Given this list of marker genes Srpk3, Slc5a10 (NCBI Gene Id 78839), Aoc3, Ppp1r27, Cend1, Rbfox3, Mroh2a, Bricd5, Mslnl, Dnlz, Mmp25, Efcab12, Spata31g1, Ftcd, Pde1b, here is a description of the gene set: studied in species Homo sapiens Tha authors analyzed RNA sequencing data to investigate the comprehensive transcriptomic landscape of Verteporfin treated Type 1 endometrial cancer cell lines, including HEC-1-A and HEC-1-B. from publication Bang LG, Dasari VR, Kim D, Gogoi RP (PMID 30846786) Mouse Gene Set: BANG_VERTEPORFIN_ENDOMETRIAL_CANCER_CELLS_DN Verteporfin is a porphyrinic photosensitizer clinically used for the photodynamic treatment of age-related macular degeneration. The authors previously tested the efficacy of Verteporfin in endometrial cancer cells and observed cytotoxic and anti-proliferative effects.